Given this list of marker genes GPER1, IP6K2, ITPKC, PTH, SCP2, CD244 (NCBI Gene Id 51744), ITPKA, P2RY1, IPMK, PLCG2, IP6K3, AVPR1B, PTAFR, IP6K1, PTH1R, NTSR1, ADCYAP1R1, PLEK, ITPKB, IPPK, PPIP5K2, PRKG1, SNCA, LHCGR, PPIP5K1, P2RY6, here is a description of the gene set: Human Gene Set: GOBP_INOSITOL_PHOSPHATE_BIOSYNTHETIC_PROCESS studied in species Homo sapiens The chemical reactions and pathways resulting in the formation of an inositol phosphate, 1,2,3,4,5,6-cyclohexanehexol, with one or more phosphate groups attached.